The following is a description of a gene set: Top 50 down-regulated genes in cluster PR of multiple myeloma samples characterized by increased expression of proliferation and cell cycle genes. studied in species Homo sapiens To better define the molecular basis of multiple myeloma (MM), we performed unsupervised hierarchic clustering of mRNA expression profiles in CD138-enriched plasma cells from 414 newly diagnosed patients who went on to receive high-dose therapy and tandem stem cell transplants. Seven disease subtypes were validated that were strongly influenced by known genetic lesions, such as c-MAF- and MAFB-, CCND1- and CCND3-, and MMSET-activating translocations and hyperdiploidy. Indicative of the deregulation of common pathways by gene orthologs, common gene signatures were observed in cases with c-MAF and MAFB activation and CCND1 and CCND3 activation, the latter consisting of 2 subgroups, one characterized by expression of the early B-cell markers CD20 and PAX5. A low incidence of focal bone disease distinguished one and increased expression of proliferation-associated genes of another novel subgroup. Comprising varying fractions of each of the other 6 subgroups, the proliferation subgroup dominated at relapse, suggesting that this signature is linked to disease progression. Proliferation and MMSET-spike groups were characterized by significant overexpression of genes mapping to chromosome 1q, and both exhibited a poor prognosis relative to the other groups. A subset of cases with a predominating myeloid gene expression signature, excluded from the profiling analyses, had more favorable baseline characteristics and superior prognosis to those lacking this signature. Human Gene Set: ZHAN_MULTIPLE_MYELOMA_PR_DN from publication Zhan F, Huang Y, Colla S, Stewart JP, Hanamura I, Gupta S, Epstein J, Yaccoby S, Sawyer J, Burington B, Anaissie E, Hollmig K, Pineda-Roman M, Tricot G, van Rhee F, Walker R, Zangari M, Crowley J, Barlogie B, Shaughnessy JD Jr (PMID 16728703), and this is the list of marker genes: ALCAM, PRDM2, SATB1, ANKRD44, FGD4, FGF2, SLC7A7, SYNE2, PPM1K, MEI1, ZBTB20, PAXIP1-AS2, PWWP2B, NR3C2, RGPD5, BLNK (NCBI Gene Id 29760), RSBN1, RASGRP3, PATJ, DUSP26, UBE2QL1, KAT2B, CBX7, EPS15, TIFA, CYLD, BAZ2B, PHF1, SMAP2, TMEM167B, SOCS1, MAP2, JMJD1C, TK2, PCDHGC3, SH3GLB1, ARHGAP18, TFEB, PLPP5, TBC1D10C, ARID5B, ZHX2, DPYD, GAB1, PLCL1, CNTN1, DDHD2, NLK, MOB3C